Given this list of marker genes Polr2k, Ercc3, Taf1, Eaf1, Polr2e, Taf4b (TATA-box binding protein associated factor 4b), Taf7l, Taf15, Nelfe, Eaf2, Supt5, Polr2c, Polr2i, Tcea1, Ctdp1, Gtf2f2, Taf7, Taf5, Gtf2h4 (NCBI Gene Id 14885), Ctr9, Supt16, Taf11, Taf8, Polr2b, Gtf2e2, Taf12, Taf13, Taf9b, Gtf2f1, Polr2l, Leo1, Nelfa, Aff4, Supt4a, Gtf2e1, Polr2a, Mllt1, Polr2f, Gtf2a1 (general transcription factor II A, 1), Ercc2, Gtf2b, Ccnh, Taf10, Taf6, Gtf2h2, Tbp, Iws1, here is a description of the gene set: part of: RNA Polymerase II Transcription studied in species Mus musculus Reactome Pathway: RNA Polymerase II Pre-transcription Events This event has been computationally inferred from an event that has been demonstrated in another species.<p>The inference is based on the homology mapping from PANTHER. Briefly, reactions for which all involved PhysicalEntities (in input, output and catalyst) have a mapped orthologue/paralogue (for complexes at least 75% of components must have a mapping) are inferred to the other species. electronically inferred by orthology from the curated human pathway